The following is a description of a gene set: species: Homo sapiens Human Gene Set: GOMF_PHOSPHATIDYLCHOLINE_TRANSPORTER_ACTIVITY Enables the directed movement of phosphatidylcholine into, out of or within a cell, or between cells. Phosphatidylcholine refers to a class of glycerophospholipids in which the phosphatidyl group is esterified to the hydroxyl group of choline., and this is the list of marker genes: ABCB4, MTTP, ATP8B2, PLTP, PITPNM1, ABCG1, ABCB1, ABCA3, PITPNB (phosphatidylinositol transfer protein beta), ABCA7, PITPNM2, SCP2, PCTP, ATP10A, TMEM63B, ATP10B, ATP8B1, ABCA1 (ATP binding cassette subfamily A member 1), PITPNC1, PITPNA